Given this list of marker genes FARSA, SON, CPLX1, RBPJ, SHANK3, UQCC3, GM2A, SSR4, SPG21, POMT2, OCRL, ABHD16A, MORC2, GALC, LIPT2, DPM2, NDUFC2, GFAP, VPS11, PSAP, FCSK, RTTN, SUMF1, NEUROD2, NSD2, TPRKB, RFWD3, DEGS1, CNKSR2, FKRP, LONP1, ARID2, KDM5A, SUGCT, SCO2, ACTA2 (NCBI Gene Id 59), LETM1, CLPB, TSEN54, PUF60, SEPSECS, SELENOI, STRADA, CNP, NRROS, GNB2, PDHB, POMT1, MPLKIP, ALDH18A1, LAMA1, PC, CLCN4, LMX1B (LIM homeobox transcription factor 1 beta), TRPM3, PLAA, MTHFR, KCNN2, PPFIBP1, ODC1, TREX1, FBXL4, TET3, RAC1, ISCA2, PDHX, MMACHC, AHDC1, AP5Z1, DLL4, AP4M1, RNU4-2, ARHGAP31, NRCAM, GTF2E2, CDK13, DPM3, TRMT1, ACTL6B, AP4E1, BRF1, COL4A1, CNBP, FGFRL1, EDEM3 (ER degradation enhancing alpha-mannosidase like protein 3), MEF2C, RNF113A, CYP27A1, DDHD2, SPG11, FA2H, CA2, HK1, ACP5, DOCK6, ARSA, NOTCH1, GMPPB, TMEM222, CTCF (CCCTC-binding factor), PRR12, RPL10, DNM1L (dynamin 1 like), PRORP (protein only RNase P catalytic subunit), ESAM, LYRM7, ZFX, AFG2B, AMPD2, TBCK, PAK1, ASL, OPA1, STXBP1, ERCC3, HIKESHI, MPV17, EOGT, CTBP1, AP4S1, AARS2, CDC42, CNTNAP2, USP7, AARS1, GTF2H5, UBA1, CARS1, WARS2, ABCD1, AP4B1, LARGE1 (LARGE xylosyl- and glucuronyltransferase 1), ERCC2, PDHA1 (pyruvate dehydrogenase E1 subunit alpha 1), TARS1, ATP13A2, ABCC9, RAB3GAP2, here is a description of the gene set: Human Gene Set: HP_ABNORMAL_PERIVENTRICULAR_WHITE_MATTER_MORPHOLOGY studied in species Homo sapiens A structural abnormality of the myelinated axons (white matter) located near the cerebral ventricles. Abnormal periventricular white matter morphology